Given this list of marker genes GHRH, GH1, IGF1, GNRH1, SST, here is a description of the gene set: Human Gene Set: WP_HORMONAL_CONTROL_OF_PUBERTAL_GROWTH_SPURT Hormonal control of pubertal growth spurt studied in species Homo sapiens